The following is a description of a gene set: Mouse Gene Set: GOBP_PLATELET_DERIVED_GROWTH_FACTOR_RECEPTOR_SIGNALING_PATHWAY The series of molecular signals initiated by a ligand binding to a platelet-derived growth factor receptor on the surface of a target cell, and ending with the regulation of a downstream cellular process, e.g. transcription. species: Mus musculus, and this is the list of marker genes: Zfand5, Fgfr4, Plekha1, Sgpl1, Ephb2, Epha4, Ros1, Met, Flt3, Gab1, Abl1, Zfp640, Nr4a3, Ret, Txnip (NCBI Gene Id 99524), Pdgfra, Itgb3, Myo1e, Ift20, Tyro3, Vegfa, Arid5b, Csf1r, Adipoq, Zfp950 (NCBI Gene Id 78823), Insrr, Ltk, Myocd (NCBI Gene Id 214384), Cblb, Erbb2, Inppl1, Ntrk2, Hip1r, Fer, Pdgfc, Lrp1, Lrig2, Epha6, Mertk, Ddr1, Ston1, Hip1, Jak2, Flt1, 2610005L07Rik, Tie1, Mst1r, Ntrk3, Kdr, Fgfr1, Flt4, Plat (plasminogen activator, tissue), Hgs, Cbl, Ptgir, Src, Csrnp1 (NCBI Gene Id 215418), Epha1, Rapgef1, Epha8, Schip1, Tiparp, Ephb4, Epha5, Igf1r, Abl2, Ptpn1, Pdgfrb, F3, Pdgfa, Epha10, Epha2, Ror2, F7, Ptpn2, Phf14, Egfr, Ntrk1, Ddr2, Npr2, Bcr, Ptpn11, Ephb3, Ndrg4, Bcar1, Mir875, Insr, Apod, Pdgfb, Fgfr2, Snca, Axl, Epha7, Smpd3, Nherf1, Alk, Erbb4, Kit, Iqgap1, Ephb1, Fshr, Epha3, Pdgfd, Lox, Fgfr3, Rgs14, Pten, Clasp2, Cspg4, Tek, Pdap1, Musk, Ptprj, Nrp1